The following is a description of a gene set: species: Homo sapiens Human Gene Set: HP_CHRONIC_FATIGUE Chronic fatigue Subjective feeling of tiredness characterized by a lack of energy and motivation that persists for six months or longer., and this is the list of marker genes: TXNRD2, RABL3, PALLD, SMAD3, MC2R, TP53, KRAS, BRCA1, BRCA2, STAR, TK2, EIF2AK4, MRAP, CDKN2A, AEBP1, PSAP, NNT (nicotinamide nucleotide transhydrogenase), IVNS1ABP, SMAD4, ALDH4A1, NLRP3 (NLR family pyrin domain containing 3), PALB2, MDM4, SMAD2, TGFBR1